Given this list of marker genes PARK7, PMAIP1, HMGB2, MAL, FGG, SP100, TMC8 (NCBI Gene Id 147138), FGA, FAIM2, GRINA, TNFAIP3, ARHGEF2, SFRP2, RAF1, STX4, FGB, RFFL, SERPINE1, THBS1, ZSWIM2, RNF34, FEM1B, MADD, HGF, GSK3B, BMPR1B, MIR222, NOS3, LGALS3, ITPRIP, CFLAR, DDX3X, GPX1, TMBIM1, HMOX1 (heme oxygenase 1), ICAM1, MIR221, STK3, SKIL, FAIM, SCRT2, BRCA1, PEA15, BMP5, SFRP1, STK4, ATF3, BCL2L1, FAF1, here is a description of the gene set: Any process that modulates the frequency, rate or extent of extrinsic apoptotic signaling pathway via death domain receptors. Human Gene Set: GOBP_REGULATION_OF_EXTRINSIC_APOPTOTIC_SIGNALING_PATHWAY_VIA_DEATH_DOMAIN_RECEPTORS species: Homo sapiens